Given this list of marker genes ATP6V0A2, ALMS1, PSMA7, SH3TC1, TUSC1, EXTL3, TRIB1, IDH1, PMF1, SLC33A1, FBXW8, SRGAP2, CA9, DPAGT1, RALA, ISYNA1, IFT122, TMBIM4, MAPK13, TTC8, PHACTR2, SPINT1, SORT1, RRM2, ACTR3, NUCB1, ARMC8, DBNDD2 (NCBI Gene Id 55861), MOB1A, PTPA, DYNC1LI2, TRPV2, DCTPP1, ILDR1, STARD3NL, DNAJB14, CD40, GALNT7, G6PC3, AVPI1, GCNT1, TM2D2, GFER, CENPB, CRYBG3, EGFL8 (EGF like domain multiple 8), CASP7, S100A1 (S100 calcium binding protein A1, NCBI Gene Id 6271), IAH1, EEPD1, SLC66A3, ATP6V1F, CYP4V2, USP22, ARHGAP32, SEPSECS, NSMF, SELENOS, TRIT1, PUS10, RAB19, TMBIM1, PGLS, ZFHX3, PLEKHO2, PGAP6, SLC25A24, LIMD1, SLC25A20, DTNBP1, GNG10, IL13RA1, TNFAIP8, CXCL10, GALE, GCA, NDUFC1, ACO1, BID, PLAAT3, FCRLA, CCDC181, FLNB, MTCH1, RPN1, FKBP15, FNDC4, ATP5MG, PTTG1IP, ATP8A1, POMP, NUDT15, PSMA3, CLDND1, NIBAN1, TUBB2B, CXCL16, ITGAV, PSME1, SMPDL3B, CENPV, HDAC9, TMEM131, MAP4K1, CNR2, PDLIM5, STT3A, NFE2L3, FKBP2, MYO18A, COP1, SESTD1, E2F1 (NCBI Gene Id 1869), FAM174A, RBBP7, SLC31A2, STX12, UBE2E1, TMED3, LPCAT1, NDST2, DNAJC16, HINT1, GOLGA7, TPST1, PDE8A, PTPRE, PARP12, RAB11A (NCBI Gene Id 8766), LANCL2, CASP3, ARHGAP17, SRGN, UMAD1, PLPP2, IL1B, COX8A, RAP2A, CREB3L2, HELLS, STRADA, DEK, CD44, AKT1, EID1, SLC8A1, SEL1L, MGAT4B, ARHGAP5, PNPO, LMAN2, IFITM2, TMEM170B (transmembrane protein 170B), PTBP2, RCN2, OSTC, ATP6V0B, SLC25A39, SLC25A10, HK3, KCTD14, RTL5, XBP1, HSP90B1, CYTH4, HAUS8, HIPK2, DPY19L4, MAPKAPK2, MIPEP (NCBI Gene Id 4285), NT5C2, RND3, EXOC3L4, ZNF516, SLC6A13, SH3BGRL (SH3 domain binding glutamate rich protein like), NOTCH2, ZNF600, C1orf21, ADAP2, LIPA, CSF2RB, SYNRG, MET, GOLIM4, SOWAHC, YWHAG, TGFB1, RNF135, SMIM30, RHOQ, MRPL17, APP (amyloid beta precursor protein), SLC22A23, CEP55, LSR, GFPT1, FRMD4A, CUL7, ELMO2, here is a description of the gene set: Goals/objectives: to identify various gene expression in B cell subsets derived from human PBMC and cord blood from publication Suryani S, Fulcher DA, Santner-Nanan B, Nanan R, Wong M, Shaw PJ, Gibson J, Williams A, Tangye SG (PMID 19965666) Genes up-regulated in naïve B lymphocytes versus those from cord blood. studied in species Homo sapiens Human Gene Set: GSE17186_BLOOD_VS_CORD_BLOOD_NAIVE_BCELL_UP